The following is a description of a gene set: species: Homo sapiens Human Gene Set: REACTOME_CIPROFLOXACIN_ADME Ciprofloxacin ADME, and this is the list of marker genes: ALB, SLC22A8 (NCBI Gene Id 9376), SLC22A1, ABCG2, SLCO1A2